Given this list of marker genes FGFR4, here is a description of the gene set: Reactome Pathway: FGFR4 mutant receptor activation part of: Signaling by FGFR4 in disease studied in species Homo sapiens FGFR4 is perhaps the least well studied of the FGF receptors, and unlike the case for the other FGFR genes, mutations in FGFR4 are not known to be associated with any developmental disorders. Recently, however, somatically arising mutations in the FGFR4 coding sequence have begun to be identified in some cancers.. The resulting mutant versions of FGFR4 promote aberrant signaling through ligand-independent dimerization and enhanced autophosphorylation, among other mechanisms.